Given this list of marker genes PPP2R1A, MDC1, PPID, RBBP4, ZNF131, ZWINT, SEC24C, CS, VDAC2, HNRNPC, IMMT, ESPL1, TARS1, SNRNP200, RBMX, ATP5PF, TBL3, HADH, THOP1, EIF4H, LARP1, PRRC2C, UBE2N, KXD1, YWHAQ, RPIA, XPO1, DDX49, VPS26A, CTBP1, SMARCC1, IARS1, WDR1, NDUFS2, HDGF, XRCC5, DKC1, SKP1, ILF2, GTF2A2, KARS1, CCT2, GLB1, U2AF1, DIAPH1, ICE1, ATP5MC1 (ATP synthase membrane subunit c locus 1), HNRNPU, SLC3A2, COPE, CYCS, SLBP, CLTA, PABPC4 (poly(A) binding protein cytoplasmic 4), R3HDM1, CEBPZ, SF3A2, RFC4, DOCK3, SF3A1, JTB (jumping translocation breakpoint), PTGES3, ESD, CHD4, EIF1AX, TM9SF2, PIEZO1, HDAC2, NARS1, EIF4EBP2, POLR2I, AK2, EIF3H, ACLY, MRPS18B, HADHA, PRKDC, KRIT1, STARD7, SCAMP3, KHDRBS1, HNRNPM, NDUFC1, CAD, HAX1, TAF11, TIAL1 (NCBI Gene Id 8430), TERF1, AP3D1, DDX19A, ILF3, GNB1, PCLAF, ERP29, CANX, HCCS, FBL, PSMB7, PRPF31, GNG5, FIBP, MRPL9, CAP1, DEK, LAGE3, ATP6AP1, HNRNPUL1, SSBP1, TNPO3, CAPZA1, TRIM28, HNRNPD, PTDSS1, SNRPA, TCP1, SNX3, NSDHL, LYPLA1, EDC4 (enhancer of mRNA decapping 4), PHB2, AP3S1, UQCRC1, PCMT1, MCM3, ACOT7, MAP2K2, EPRS1, NUP188, ERCC5, CIAO1, CYC1, PPP1CC, UBAP2L, DEAF1, COPS5, HYOU1, PPIG, PPT1, EIF3E, SRSF1, YARS1, GNB2, TXNL4A, MTREX, DDX19B, ACTR3, GPN1, IRAK1, SRP72, EI24, FAM120A, DYNLL1, NCL, RNF126, DNAJC9 (DnaJ heat shock protein family (Hsp40) member C9), BAG6, CDC16, BUB3, SUMO1, ANP32A, SF3B2, LRPPRC, GCN1, EIF3B, MGRN1, TRAPPC3, TUFM, TREX2 (three prime repair exonuclease 2), ELOC, TARDBP, ACP1, NDUFS5, NDUFS4, PTPN11, HADHB, UPF3A, RO60, NDUFB3, DR1, SEM1, RUVBL2, LSM4, DNMT1, GPAA1, NDUFA7, ATP5PO, SLC1A5, DUT, CHERP, DNAJC8, AKR7A2, VDAC3, KHSRP, NUDT1, SREBF2, HNRNPR, MAGOH, FAM168B, PRPS2, ANP32B, RSL1D1, EIF3I, PUF60, DRG1, F8A1, XPO7, RPN1, SRRM1, NONO, KIFC1, FUS, CHMP2A, TFDP1, NRDC, DDOST, NSMAF, TUBA3C, AHSA1, LMNB2, RNPS1, G3BP2 (G3BP stress granule assembly factor 2), MAPRE1, CDC123, UBA2, SNRPE, TOMM70, EIF2S2, NDUFS3, POLA2, MCM2, DNAJC11, DHX38, IMPDH1, GANAB, FARSA, SNRPA1, TTC1, AFG3L2, CSK, ATXN10, BAZ1B, XRCC6, BZW1, RAD23A, RNPEP, DDX39A, UQCRH, POM121, NUP205, ARF3, DGUOK (NCBI Gene Id 1716), MFAP1, DDX1, SMC1A, EIF4A1, MDH1, MTDH, HDDC2, PPM1G, TEX261, NPM3, SERP1, IDH3G, SET, PARK7, SSB, AP2S1, H2AZ1, PKN1, PPIE, IFRD1, PDIA6, ATP5F1D, PREP, NAA10, MCM6, HAT1, NDUFV1, SUMO2, BCAP31, PDHB, ANAPC5, NUDC, MRPS12, AATF, NDUFS8, GMPS, CLPP, SLC25A3, SOD1, HDAC1, H2AZ2, NSD2, UBE2L3, EIF3K, DCTD, GARS1, VDAC1, HSPA9, VBP1, PRDX3, TOMM20, SAFB, DHCR7, GLO1, HNRNPA3P1, GOT2, TYMS, UQCRFS1, FH, XPOT, LSM2, HNRNPAB, DGKZ, PABPN1, HNRNPA2B1, PMEL, CCT5, CTDNEP1, RHEB, RAN, CALM3, SMNDC1, POLR2A, SMARCD2, RTCB (RNA 2',3'-cyclic phosphate and 5'-OH ligase), TCEA1, DDX39B, SDHA, PSMB2, UBAC1, CCT7, CSNK2B, CBX3, MTCP1, SDHB, DARS1, DHX15, POLE3, SRSF9, SDHD, PAPSS1, PPIF, NDUFV2, TMED9, IDH3B, PRPF8 (pre-mRNA processing factor 8, NCBI Gene Id 6108), ATP5MC3, here is a description of the gene set: Neighborhood of RAD23A Human Gene Set: MORF_RAD23A Neighborhood of RAD23A RAD23 homolog A (S. cerevisiae) in the MORF expression compendium species: Homo sapiens